Given this list of marker genes HSPA1L, CCT8, ZPBP2, TCP1, CCT2, ZPBP, CCT4, CCT3, here is a description of the gene set: species: Homo sapiens A multisubunit complex comprising the chaperonin-containing T-complex and several other components involved in mediating sperm-oocyte Interaction. Human Gene Set: GOCC_ZONA_PELLUCIDA_RECEPTOR_COMPLEX